The following is a description of a gene set: Genes having at least one occurrence of the motif KGGGTGGTC in the regions spanning 4 kb centered on their transcription starting sites. This matches the ZIC1 transcription factor binding site V$ZIC1_01 (v7.4 TRANSFAC). studied in species Homo sapiens Human Gene Set: ZIC1_01, and this is the list of marker genes: CPEB3, CDKN1B, DVL2, TMEM126B, CACNG3, FCGR3B, HOXB9, FAM83H, YARS1, KCND1, ABHD8, PTCH1, TRAF4, TMEM151A, EIF5A, DRD1, NOTCH1, FMNL2, LEF1, PRDX5, LMNA, PRMT1, PTCH2, TTC16, SEMA3B, LINC00649, DUSP11, MIR22HG, TENM3-AS1, POU2F1, NXPH3, CTDSPL2, MTUS1, CGGBP1, EFNA4, CASKIN2 (NCBI Gene Id 57513), PACSIN1, DNAJB5, RTL9, NKX2-2, GEMIN4, TSC22D4, KCNK10, EIF4G1, DSG1, ZNF362, PTK7, CUEDC1, PICALM, NTN3, PAK4, KAZN, FGF10 (fibroblast growth factor 10), IPO13, SLC38A3, UBE2R2, ANKRD13A, MBNL1, ATP2B4, CTNND1, BTG1 (BTG anti-proliferation factor 1), METTL4, SH3BP1, NLGN3, PGF, SLC4A1, KDM6A, DCTN1, FADS3, ARHGEF17, WNT10B, EYA4, LRP8, BMPR2, ASB7, HSPB2, PCDHGA2, STAR, KCNH2, PMP22, PLA2G3, AP1S2, MAP1B, OVOL1, GHR, TMEM255A, DEF8, CPNE1, ATL1, CTNND2, CILP2, TAOK2, ZNF318, SALL1, LGI1, CCNYL1, RALY, ACSL4, MYOC, RGS14, CDK6, KCNJ14, NRG1, PTPN1, CCDC106, ZMYND11, MAEA (macrophage erythroblast attacher, E3 ubiquitin ligase), EFEMP2, GATA6, DGKH, KIF3C, RHO, WDR13, YWHAG, MAP1A (NCBI Gene Id 4132), PTGR3, HPCA, CCDC102A, CTNNA3, MSL2, PLXDC2, MAML3, PDGFB, HOXA10, FCGR3A, KCNA1, DQX1, PPP1R10, CRB2, NEGR1, SAP130, GJB1, RBM12, DMTF1, HNRNPD, USP21, ZNF654, USP51, HOXD9, SZT2, RAB11A, CCDC88A, SIPA1, LRP1, OSTC, LINC01312, CYP26A1, PHF12 (PHD finger protein 12), PRAF2, HCST, GNL3LP1, TGIF2, RRM1, UCHL3, KLF12, FSTL3, AEBP2, THRAP3, USP49, TLK2, FASTK, NFKBID, BRWD3, ZMYM2, TPM2, HYCC1, GIT1, KLF13, FES, UNC5C (NCBI Gene Id 8633), NELL2, PHEX, BCOR, MARCHF5, GABRG2, ERBB3, GRIN2D, HOXA7, MAGED1, P2RX1, ZMYM3, BAHD1, CCDC71L, ARHGAP45, NDUFA4L2, NKX2-8 (NCBI Gene Id 26257), VEGFA, BCL6, NOL4, PI4KB, GNAO1, ERBB4, LINS1, MCRS1, NFYA, UTP18, GIGYF2, TUG1, ETV6, PCBP4, KANSL3, DCTN3, DHX30, FUT2, TYRP1, ARL5B, ZNF384, SHISA6, SUPT16H, SLC4A2, RSPRY1, PRDM10 (NCBI Gene Id 56980), FRAS1, TRAF3IP2, SLIT3, LMAN2L, MAF, FAM110D, DYNLL1, RAB1B, IL11, LAMC2, CYB561D1, CRYAB, OARD1, CA10, RCOR2, COL7A1, WDR81, S100A4, SPRY4, NLGN2, SAMD12, ZNF503, FANCD2, SCGB3A1, TRERF1, HELZ2, GLI1, CTTNBP2NL, WNT8B, CA14, RORA (RAR related orphan receptor A), HEXIM2, ZDHHC12 (zinc finger DHHC-type palmitoyltransferase 12), TUFM, CDK18, DLL4 (delta like canonical Notch ligand 4), MRPS18B, KCND2, HOXC11, LAT, CYP26B1 (NCBI Gene Id 56603), TRMT112, NTN1, TAFAZZIN, ATXN7L1, HOXB8, MID1IP1, C20orf173, PSME3IP1, ZFHX3, CXXC5, PAGR1, ATP6V0A4, CBLN1, CERCAM